Given this list of marker genes CD200, CD200R1 (NCBI Gene Id 131450), CD69, APOD, IL27RA, RIPOR2 (RHO family interacting cell polarization regulator 2), LRCH1, here is a description of the gene set: Human Gene Set: GOBP_NEGATIVE_REGULATION_OF_T_CELL_MIGRATION species: Homo sapiens Any process that stops, prevents or reduces the frequency, rate or extent of T cell migration.